Given this list of marker genes IL7R, IFITM2, UNKL (NCBI Gene Id 65259), CD22, RUBCNL, CXCL13, P2RY10, AXIN1, HVCN1, MECP2, LIMD2, CCL18, KIAA0753, NLRC5, KLRK1, FCRLA, IFITM3, CD79A, IFI44, IFIT1, CD86, KCTD12, TCL1A, TXLNGY, CD74, HLA-DPB1, CD200, GNLY, CD79B, IGHG3, IFI35, PLSCR1 (phospholipid scramblase 1), PELI1, IFIT5, KCNQ5, FAM53B, RRP15, CXCL9, LPAR6, FPR1, BANK1, UCP2, CCL7, DGKA, TNFSF10, SERPINA5, CAMK4, LCK, APOL3, CD14, BLNK, PPP1R16B, ATP2A3, HLA-DQB1, FADS1, CD37, HLA-DMB, IL2RB, ISG15, HLA-DQA1, IGKC, XCL1, STAG3, CARD16, HLA-DMA, FOXP1, HAUS6, CACNG4, SDC2, HLA-DRA, CD24, CTSL, IGHM (NCBI Gene Id 3507), LSP1, NEK11, IGLL1, ABTB1, CD2, ADAM19, OAS3, GBP2, IGLJ3, CD19, HLA-DPA1 (major histocompatibility complex, class II, DP alpha 1), MS4A1, CD48, LGMN, CCDC186, FCRL2, SAMSN1, STK31, CEBPD, MMRN2, SELL, CNRIP1, DEFA1, PTPRCAP, POU2F2, USP30, IFI44L, ICAM3, UTY, TNFAIP6, VCAM1, PNMA8A, MAL, TTLL2 (tubulin tyrosine ligase like 2), POLR3B (NCBI Gene Id 55703), CYP1B1, CD3D, SPIB, IFT70A, MX2, IL16, TPTE2, IL3RA, UNC79, HELZ2, SP140, CD27, UCP1, UNC5D, OAS1, CSF3 (colony stimulating factor 3), ADGRE2, CD5, THBS1, CD72 (NCBI Gene Id 971), HBA2, TNFRSF25, ST6GAL1, AQP9 (aquaporin 9), GBP1 (guanylate binding protein 1), IFITM1, TREM1, MYCBP2, here is a description of the gene set: Human Gene Set: MODULE_292 studied in species Homo sapiens Genes in the cancer module 292.